Given this list of marker genes SLC39A14, TCEAL1, SLC52A3, GCSH, HTT, SELENOI, PEX16, NFU1, NT5C2, SPAST, NDUFS8, POU3F4, VCP, GALC, CYP7B1, STUB1, CD40LG, KPNA3, FA2H (NCBI Gene Id 79152), ERLIN2, SMG9, ATP6AP2, MARS1, KIF1C (NCBI Gene Id 9713), SLC16A2, AHDC1, SLC1A4, PI4KA, PLA2G6, RAB18, FGF13, GFM2, SYNE1, ERLIN1, SPG11, VAC14, KLC2, KIF5A, ABCD1, PIGT, RTN2, AARS1, CCDC88C, SAMD9L, SOD1, TIMM8A, PSAP, COQ4, UCHL1, CAPN1, REEP1, ANO10 (NCBI Gene Id 55129), SPART, SV2A, KIF1A, SPTBN2, CYP27A1, GBA2, ADGRG1, ATL1, CARS1, here is a description of the gene set: Human Gene Set: HP_ANKLE_CLONUS Ankle clonus studied in species Homo sapiens Clonus is an involuntary tendon reflex that causes repeated flexion and extension of the foot. Ankle clonus is tested by rapidly flexing the foot upward.